The following is a description of a gene set: Any process in which an organism has an effect on an organism of the same species. Human Gene Set: GOBP_BIOLOGICAL_PROCESS_INVOLVED_IN_INTRASPECIES_INTERACTION_BETWEEN_ORGANISMS species: Homo sapiens, and this is the list of marker genes: BBS4, GRID1, BRINP3, NPAS4, ATXN1L, CHD8, NLGN4Y, DSCAM, PIANP, GABRB3, DVL1, VPS13A, TBX1, DRD4, NR2E1, MKKS, MECP2, NEGR1, NRXN2, GAREM2, GNB1L, KCNQ1, GRP (NCBI Gene Id 2922), LTF, ATXN1, MAPK8IP2, BRINP1, SHANK3, PTEN, DLG4, RPTOR, PTCHD1, UCN, NLGN3, BPIFA1, CIC, NLGN2, SHANK1, AVPR1A, GAD1, NRXN1, CHRNB2, CX3CR1, PCM1, NRXN3, CNTNAP2, CLN8, EIF4EBP2, SEPTIN5, GNG8, OXT, GRPR, VPS13B, TREM2, EFR3B, EN1, EXT1, NLGN4X, DRD3, SHANK2, AVP